The following is a description of a gene set: Mouse Gene Set: GOBP_DETOXIFICATION_OF_INORGANIC_COMPOUND Any process that reduces or removes the toxicity of inorganic compounds. These include transport of such compounds away from sensitive areas and to compartments or complexes whose purpose is sequestration of inorganic compounds. species: Mus musculus, and this is the list of marker genes: Muc2, Abcb6, Cat, Abcc2, Atp7a, Park7, Mt1, Slc30a1, Slc39a8, Slc30a10, Slc11a1, Mt2, Slc30a3, Mt4, Mt3, Txn1